The following is a description of a gene set: The lipid bilayer surrounding a microbody. Mouse Gene Set: GOCC_MICROBODY_MEMBRANE species: Mus musculus, and this is the list of marker genes: Pxmp4, Pex6, Arf1, Pex10, Pex11b, Tmem135, Plaat3, Acsl1, Abcd3, Decr2, Syt7, Hmgcr, Pex1, Abcd1, Pex14, Pex3, Cat, Slc25a17, Agps, Pex11g, Far2, Tmem35a, Pex2, Pex19 (peroxisomal biogenesis factor 19), Slc22a21, Nbr1, Pjvk, Acox1, Slc27a2, Acsl4, Mavs, Pex5, Pex11a, Cav1, Rab8b, Acbd5, Acsl3, Pex12, Pex26, Pex13, Mgst1, Trim37, Abcd4, Gnpat, Pex5l, Fndc5, Dhrs4, Pex16, Pecr, Acsl6, Pnpla8, Mpv17l, Atad1, Far1, Abcd2, Fis1, Pxmp2